The following is a description of a gene set: studied in species Homo sapiens Tgif disruption of Shh signaling Human Gene Set: WP_TGIF_DISRUPTION_OF_SHH_SIGNALING, and this is the list of marker genes: GLI3, SHH, FOXG1, NODAL, NKX2-1, SMAD2, TGIF1, TGIF2, FGF8